Given this list of marker genes Slc5a1, Slc2a10, Slc2a1, Slc2a5, Slc5a2, here is a description of the gene set: Mouse Gene Set: GOBP_CARBOHYDRATE_IMPORT_ACROSS_PLASMA_MEMBRANE studied in species Mus musculus The directed movement of a carbohydrate from outside of a cell, across the plasma membrane and into the cytosol.